Given this list of marker genes NFKB2, REL, CHUK, RELA, IKBKE (NCBI Gene Id 9641), NFKBIB, RELB, NFKBIA, NFKB1, NFKBIE, IKBKB, IKBKG, BCL3, here is a description of the gene set: Human Gene Set: GILMORE_CORE_NFKB_PATHWAY Genes encoding the NF-kB core signaling proteins. This article serves as an introduction to the collection of reviews on nuclear factor-kappaB (NF-kappaB). It provides an overview of the discovery and current status of NF-kappaB as a research topic. Described are the structures, activities and regulation of the proteins in the NF-kappaB family of transcription factors. NF-kappaB signaling is primarily regulated by inhibitor kappaB (IkappaB) proteins and the IkappaB kinase complex through two major pathways: the canonical and non-canonical NF-kappaB pathways. The organization and focus of articles included in the following reviews are described, as well as likely future areas of research interest on NF-kappaB. from publication Gilmore TD (PMID 17072321) studied in species Homo sapiens